Given this list of marker genes EPHA3 (EPH receptor A3), CFL2, IGF2BP3, ETF1, BNIP3, FGFR1OP2, SMG1, PDZRN4, DTWD2, DUS4L, CISD2, PPHLN1, CDK6, GUCY1A2, ODAPH, PDCD5, SF3A1, SERINC5, GABPB1, ARL6IP6, CHRNA7, PTPRG, GPSM2, GASK1A, RNF149, ZNF486, SLC4A7, RGPD8, ZBTB25 (NCBI Gene Id 7597), CACUL1, PTPRR, RGPD5, GOPC, PRKAG2, NFKB1, S1PR1, CCDC179, CBX3, GATM, DUSP7, SEC24A, TTC19, TRIM2, LRRC4B, FRMD5, DEFA6, ZNF326, STXBP5, SLC24A3, MBIP, NUP50, SCML2, RBBP8, CLVS2, ZNF680, KLF10, SCAMP1, ARFRP1, SAMTOR, MZT1, ITGB6 (NCBI Gene Id 3694), EDIL3, ZBTB11, LPP, SCARF1, FNIP2, ZDHHC21, PAQR9, MED6, TBCA, NEGR1, PSMC2, TMEM135, CAMLG, CA8, CLCN4, WDR26, GABRA4, GPR85, COMMD3-BMI1, SPATA6L, SANBR, POLR2H, RALA, DYNC1LI2, ZBTB41, GRID2, KIAA1586, BOD1L1, C3orf38, IKBIP, PRKAA2, ZDHHC2, EEA1, PGRMC2, ACBD3, PRELID2, PHYHIPL, FBXL3, PITX2, ATXN2, C21orf91, SNX30, NUMB, CSNK1D, GPALPP1, ZBTB20, JARID2, SCN8A, MGARP, YIPF5, HECA, ELL2, KIF20B, DHRS1, TMTC3, CARF, GSTCD, AQP3, CNTN1, HDAC9, NRXN1, RORA, ZNG1E, PPP1R2, DAAM1, BCL2L2, ACTN4, EVI2A, SPOCK3, EXOC5, ZNF608, SYNM, NUP54, GLIPR1, MECP2, MMUT, BEND7, UGDH, TMEFF2, KLF7, DIAPH3, PAPOLG, HTR2C, ASB3, ZNF492, TRIM9, MEX3D, PROSER1, GPATCH11, MTA1, SFT2D1, SLC30A5, CBFB, COL11A1, TLCD4, WAPL, C5orf24, FZD3, ARL13B, MAGT1, RO60, OGFRL1 (opioid growth factor receptor like 1), CLDN12, GPR155, CACNA2D3, LACTB, SDC2, TMEM200A, UNC80, CIAO2A (cytosolic iron-sulfur assembly component 2A), GRM7, UBE2A, PRRC1, FYB2, CAMSAP2 (calmodulin regulated spectrin associated protein family member 2), PCDH11X, CCNG2, SCN3A, RAP1A, RHPN2, ZNF652, CFAP44, BBX (NCBI Gene Id 56987), IKZF2, ZBTB10, RGS7BP (NCBI Gene Id 401190), MMD, SREK1, AK3, LCTL, GSE1, RGPD6, MAST3, LMCD1, PROK2, SETD2, PDE4D, SPDYE1, PRKG1, PRKAA1, SPAG9, SH3D19, TMEM167B, LRRTM3, PRPF40A, ACADL, SKIDA1, CSGALNACT2 (NCBI Gene Id 55454), RICTOR, ZNF559, BTG2, LCOR, CYBRD1, RASSF8, EPB41L5, SEC22C, DYNC1I2, FNDC3B (fibronectin type III domain containing 3B), MARCHF6, NEDD4L, TRAM1, CCDC117, GABPA, MTF1, FGD4, NOS2, POU2F1 (NCBI Gene Id 7823), BRWD3, NAV2, SERBP1, NAA30, ANKRD10, TCF12, HOMER1, PAX5 (NCBI Gene Id 5079), THSD7A, ZNG1A, TOLLIP, PTBP3, GTF3C3, SNX16, WDR47, PDE1C, SERINC3, RAB27B, BMI1, MDFIC, ARID2, LRRC7, PRP4K, LIN7A, ADH5, WDR7, KLRD1, NTF3, UGT8 (NCBI Gene Id 7368), CCNB1 (NCBI Gene Id 891), MYCN, CEP350, MFN1, ARK2N, SFMBT1, SACS, FAM221A, PCLO, ANKRD22, ZNF792, SMAD5, SYTL5, SH3BGRL, TFDP3, LSAMP, PLEKHG1, ADAM30, NR2C1, SGIP1, ZBTB44, MCF2L2, TMTC1, SRSF6, GPC6, CCDC47, ZNG1B, HOXD13, GUCY1B1, PTGFRN, KRT28, CD99, SENP1, AIDA, KLF8, GAPVD1, AHSA2P, SESTD1, GCNT1, UTP3, METTL8, AFDN, TBCK, MIER1, LANCL1, KATNBL1, SRP9, PIWIL3, BBS10, TRA2B, ZNF503, AGTR1, ADAMTS1, ZEB2, KL, DIP2B, PPP5C, SNAP91, ALG11, GRM5, NAT1, CERS6, BTG3, RNF217, TMED7, SUMF1, ADAMDEC1, C11orf87, FZD7, CFDP1 (NCBI Gene Id 10428), SOX5, RC3H1, GOLGA6L2, GRIP1, FAM111A, ZFAND5, MAP9, ZNG1C, LARP4, CTNNA3, ANKRD46, FIGN, PREX2, CD163, FZD5, TTC13, RAB8B, ERC2, HLTF, MIER3, MFSD8, MAML1, U2SURP, URI1, SRSF3 (serine and arginine rich splicing factor 3), ADAM22, MAP4K4, MEIS2, CHN1, SAMD8, APPBP2 (amyloid beta precursor protein binding protein 2), RFX7, ANGEL2, RESF1, LATS1, KPNA4, FAM133A, IGSF3, RIMOC1, TFAM, NDFIP2, ZNG1F, GPD2 (NCBI Gene Id 2820), MINDY2, RRAGD, MAST4, RAP2A, HOOK3, MIDEAS, RAD54B, DNAJB14, TIFAB, ACAT2, PGAM1, CCNY, RMND5A, LVRN, TRPC5, RPS6KA5, ANKRD26, SECISBP2L, CCSER1, ZRANB2, ZCCHC8, NCKAP1, SCN1A, ME1, FMNL2, ARRDC4, SDE2, REV3L, SIX4 (SIX homeobox 4), FLRT3, ABCA5, PPEF2 (protein phosphatase with EF-hand domain 2), DCUN1D5, SDF4, XPNPEP1, C6orf120, ADGRB3, DPY19L3, CCP110, SLCO5A1, TPM3, CRIPT, GNAQ, TMEM65, FSBP, B3GALT5, DNAJB4, LMX1A, DDIT4, DCDC2, MBNL3, RIC1, PPARG, CHST7, CHST9, MIGA1, BTF3L4, CCDC50, SLU7, GULP1, STYX, TNFRSF21, OAZ1, RNF138, PLEKHH2, ITGAV, NDC1, ZNF454, PCDH11Y, DOLPP1, SLAIN1, SMAD9, MMP16, ZNF148, GCC2, ATP11A, ONECUT2, FGL2, CLVS1, TXLNG, ARMCX3 (NCBI Gene Id 51566), UEVLD, C9orf40, NOTUM, SSR3, NOTCH2, ANAPC1, MTFR1, STEAP2, HIPK1, PPP1R27, FEM1C, TMEM255A, PRPF39, AP1AR, FAM199X, AFTPH, HMBOX1, ZNF747, PPP1R9A, TP53INP1, NFAT5, MBNL2, CEP120, NRG4, MTMR6, UBA6, RGPD4 (NCBI Gene Id 440893), ACVR2B, ATXN7L1, CAPN2, HNRNPDL, RETREG1, A1CF, METTL6, FOXG1, IGF1, TRPC1, BRWD1, FAM135A, TRUB1, RHOQ, LACTB2, DENND1B, ZC3HAV1L, CMPK2, ACBD5, EIF2AK2, NUP160, CRACD, ABI3BP, LRP1B, ZDHHC15, RFC3, KCNJ3, here is a description of the gene set: Human Gene Set: MIR548Y Genes predicted to be targets of miRBase v22 microRNA hsa-miR-548y in miRDB v6.0 with MirTarget v4 prediction scores > 80 (high confidence targets). from publication Chen Y, Wang X (PMID 31504780) studied in species Homo sapiens